The following is a description of a gene set: from publication Chen Y, Wang X (PMID 31504780) Human Gene Set: MIR384 Genes predicted to be targets of miRBase v22 microRNA hsa-miR-384 in miRDB v6.0 with MirTarget v4 prediction scores > 80 (high confidence targets). species: Homo sapiens, and this is the list of marker genes: RBM18, VPS53, MS4A8, ATE1, SPATA1, SH3BGRL2, LPAR1, ANKRD20A4P, SPATS2L, NIF3L1, CEP135, NLK, RSU1, GSTCD, IPO8, POGZ, RCAN2, RORB, FAM199X, STX2, SLITRK4, TIMP3, PDE4D, TMEM33, LRP2, ZNF597, PYHIN1, SRGAP3, TENM1, NEK4, SOHLH2 (NCBI Gene Id 54937, spermatogenesis and oogenesis specific basic helix-loop-helix 2), SLCO6A1, COQ2, SEC62, RBM19, PPM1M, TNFAIP1, OPRM1, SNTB1, VAMP3, DNAJC25, PICALM, MACIR, KCNJ10, EPPK1, ULK2, SLC35F1, AAK1, NSL1, CC2D1B, ANKRD20A3P, ANKRD20A1, EPC2, OR2A4, PTN, PRKACB, CCPG1 (cell cycle progression 1), GTF2B, GTF2H3, ADARB1, OXSR1, LRRK2, SPAST, DIRC1, POU2F1, ASAP2, PGAP1, KLHL9, PRTG, RHOBTB3, MTPAP, HDGF, ARK2N, HMGCLL1, CISD1, OXR1, THBS1, POU2F3, POM121, METAP2 (NCBI Gene Id 10988), PIWIL4, PIGK, NCAM1, TLR3, TAP2, CCDC169-SOHLH2, SYNGAP1 (NCBI Gene Id 8831), CLIP1, CISD2 (NCBI Gene Id 56831), ZNF629, GPM6B, MATN2, SERF2, ANKRD20A2P, PRR16, ABCG1, MAPK9, C4orf46, HIRA, KRT73, WDR44, RFXAP, LYVE1, BPNT2, ZKSCAN4, STRN3, WDR7, SHANK2, SYTL2, HOXB2, CFTR, CENPQ, SLC35A5, PDE5A, LIFR, HERPUD1, SLC30A4, DCUN1D5, STON2, NFAT5, ACSL3, HTR2C, EAF1